The following is a description of a gene set: species: Homo sapiens Human Gene Set: HP_TRIPHALANGEAL_THUMB Triphalangeal thumb A thumb with three phalanges in a single, proximo-distal axis. Thus, this term applies if the thumb has an accessory phalanx, leading to a digit like appearance of the thumb., and this is the list of marker genes: UBE2T, FANCF, FANCL, FANCI, RPL26, DLX5, DACT1, RPS29, FANCD2, ERCC4, BRCA2, HEATR3, BRIP1 (NCBI Gene Id 83991), RPL31, TBX5, RPL11, RPL18, RAD51, LMBR1, BRCA1, PIGF (phosphatidylinositol glycan anchor biosynthesis class F), RPS24, FANCC, RAD51C, RPS7, TBC1D24, RPS19, RPL5, TSR2, PIGB, SHH, RPL8, MSX2, PALB2, FANCE, FANCG, RPL9, SALL4, RPS15A, FANCA, MAD2L2, ADA2, GLI3 (GLI family zinc finger 3), RPS20, FANCM, SLX4, FGFR2, KCNN3, RPS28, RPL15, MAFB, GATA1, XRCC2, FANCB, TP63, RFWD3, RPL27, FGFR3, CHN1, RPS10, KIF7, RPL35A, RPL35, SALL1, ATP6V1B2, TWIST1, RPS27, SF3B4, RPS26, RPS17